Given this list of marker genes H2ac1, H2bc13, H3c15, Hcfc1, H2az2, H4c14 (NCBI Gene Id 97122), H2bc8, Kansl1, H2ac11, H4c6, Hcfc2, H3c11, Kansl2, H2ac10, Ncor2, H2ac24, Paxip1, Phf20, H4c18, H3c7, H2ac13, Wdr82, H4c11, Tbl1x, Kmt2b, Setd1a, H3c6, H2ac19, H2bc11, Pparg, H2bc3, H3c13, H2bc22, H2ac12, H4c3 (NCBI Gene Id 319155), H2bc9, H2ac6, H2bc12, H2bc7, Phf20l1, H2ax, H3c4, H4c2, H4c12, Sgf29, H4c8, H4c17, Ash2l, H2bc15, Gps2, H3c1, H2bc27, Men1, H2ac22, H3c3, H2ac4, Tada2a, H2ac20, H2bc1, H3c2, H2ac7, H2ac23, H2ac15, H4c4, Kdm6a, H4c9, H3c10, H4c1, H3f3a (NCBI Gene Id 15078), H3c8, Hdac3, H2ac8, here is a description of the gene set: species: Mus musculus part of: Epigenetic regulation of gene expression electronically inferred by orthology from the curated human pathway Reactome Pathway: Epigenetic regulation by WDR5-containing histone modifying complexes This event has been computationally inferred from an event that has been demonstrated in another species.<p>The inference is based on the homology mapping from PANTHER. Briefly, reactions for which all involved PhysicalEntities (in input, output and catalyst) have a mapped orthologue/paralogue (for complexes at least 75% of components must have a mapping) are inferred to the other species.